The following is a description of a gene set: Human Gene Set: GOBP_DETECTION_OF_EXTERNAL_BIOTIC_STIMULUS species: Homo sapiens The series of events in which an external biotic stimulus is detected and converted into a molecular signal. An external biotic stimulus is defined as one caused or produced by a living organism other than the one being stimulated., and this is the list of marker genes: PGLYRP1, NAIP, TLR6, LBP, TLR1, CLEC7A, CLEC6A, LY96, SCARB1, TLR4, NLRC4, TREM2, C4B, HLA-DRB1, NOD2, TLR2, HLA-B, HLA-A, PGLYRP4, NR4A1, SSC5D, PGLYRP2, PGLYRP3, CD1D, NOD1, TLR9